Given this list of marker genes Prkaa1, Sirt3, Sox4 (NCBI Gene Id 20677), Dip2b, Prkaa2, Sirt1, Hint2, Dip2a, Nfe2, Hdac2, Pml, Klf15, here is a description of the gene set: Mouse Gene Set: GOBP_REGULATION_OF_PEPTIDYL_LYSINE_ACETYLATION Any process that modulates the frequency, rate or extent of peptidyl-lysine acetylation. studied in species Mus musculus